Given this list of marker genes CSF3, IL34, IL10RB, TXLNA, IL32, CD4, STX4, PRTN3, JAK1, STXBP2, TYK2, VAMP2, IL16, CSF1, IFNL1, PTPRZ1, CSF1R, STX3, CSF3R, IFNLR1, CASP3, SDC1, SNAP25, STX1A, here is a description of the gene set: Human Gene Set: REACTOME_OTHER_INTERLEUKIN_SIGNALING studied in species Homo sapiens Other interleukin signaling